Given this list of marker genes DHX57, ANAPC11, HEATR6, NME1, SOS1, SLC35F6 (solute carrier family 35 member F6), NCOR1, PIGL, HSD17B1, TUBD1, CD300LF, EPN2, GPS1, CCR7, TMEM97, MRPS23, BIRC6, RPL38, ALYREF, PAFAH1B1, CCDC47 (NCBI Gene Id 57003), GTF3C2, PRR11, SCO1, STX8, EIF4A3, CDC6, GJC1, FOXK2, SCPEP1, CTDNEP1, WSB1, CA10, MAP2K3, MCRIP1, WIPF2, ICAM2, KPNB1 (karyopherin subunit beta 1), SEC14L1, CEP95, SRP68, UTP18, SGSH, KIF18B, PHF23, EME1, PITPNA, STAT3, BRIP1, MRPL58, SRR, MYO1C, MRPL27, TACO1, MRPS7, NDUFAF8, NME2, JPT1, FLII, ARL16, SLC30A6, GAS7, MRPL10, PPM1D, BPTF, ANKFY1, MINK1, HCRT, MED9, PYCR1, NCBP3, LUC7L3, RPL23, ETV4, ACBD4 (acyl-CoA binding domain containing 4), MKS1, INTS2, BRCA1, EZH1, NTN1, SLC25A19, ATP2A3, SLC25A10, SNHG16, TMEM220, VTN, CTC1, POLG2, ANKFN1, AXIN2, HEXIM1, GOSR2, NUP85, MIR497HG, MYO18A, SMCR8, DUS1L, PSMC5, ALDH3A2, ATPAF2, CCL14, ZBTB4, ABCC3, NEURL4, NEK8, ALDOC, GPATCH11, SMURF2, KPNA2, ATP5MC1, SMC6 (structural maintenance of chromosomes 6), TMEM106A, LINC02210, GPRC5C, KSR1, FTSJ3, BAIAP2, SRSF2, SYNRG, SUMO2, TSEN54, AKAP1, LRRC59, EFCAB13, MRPL38, RNASEH1, ASGR1, NAT9, DHX40, ANKRD40, DHRS7B, SUPT4H1 (NCBI Gene Id 6827), TNFSF13, TOP2A, TK1, CBX2, RPS6KB1, GOSR1, PTRH2, TOM1L2, UTP6, RNF135, JMJD6, TIMM22, MRPL12, PHB1, NDEL1, CCDC144NL-AS1, NOL11, TMEM199, LBH, ARHGAP23, SLC38A10, RFFL, UBE2O, ULK2, KRTAP4-8, TBX2, TNFAIP1, BIRC5, ACADVL, MAP2K4, MSI2, ZNF18, MED13 (NCBI Gene Id 9969), MGC16275, RAD51C, P4HB, ATP5PD, RASD1, CRK, ARMC7, CHRNB1, TRPV2, GPS2, GEN1, DPH1, DCAF7, KHK, TRAPPC1, SMG8, FLOT2, RAB10, PMP22, SRSF1, here is a description of the gene set: Genes with copy number gains in primary neuroblastoma tumors. Human Gene Set: LASTOWSKA_NEUROBLASTOMA_COPY_NUMBER_UP species: Homo sapiens Identifying genes, whose expression is consistently altered by chromosomal gains or losses, is an important step in defining genes of biological relevance in a wide variety of tumour types. However, additional criteria are needed to discriminate further among the large number of candidate genes identified. This is particularly true for neuroblastoma, where multiple genomic copy number changes of proven prognostic value exist. We have used Affymetrix microarrays and a combination of fluorescent in situ hybridization and single nucleotide polymorphism (SNP) microarrays to establish expression profiles and delineate copy number alterations in 30 primary neuroblastomas. Correlation of microarray data with patient survival and analysis of expression within rodent neuroblastoma cell lines were then used to define further genes likely to be involved in the disease process. Using this approach, we identify >genes within eight recurrent genomic alterations (loss of 1p, 3p, 4p, 10q and 11q, 2p gain, 17q gain, and the MYCN amplicon) whose expression is consistently altered by copy number change. Of these, 84 correlate with patient survival, with the minimal regions of 17q gain and 4p loss being enriched significantly for such genes. These include genes involved in RNA and DNA metabolism, and apoptosis. Orthologues of all but one of these genes on 17q are overexpressed in rodent neuroblastoma cell lines. A significant excess of SNPs whose copy number correlates with survival is also observed on proximal 4p in stage 4 tumours, and we find that deletion of 4p is associated with improved outcome in an extended cohort of tumours. These results define the major impact of genomic copy number alterations upon transcription within neuroblastoma, and highlight genes on distal 17q and proximal 4p for downstream analyses. They also suggest that integration of discriminators, such as survival and comparative gene expression, with microarray data may be useful in the identification of critical genes within regions of loss or gain in many human cancers. from publication Łastowska M, Viprey V, Santibanez-Koref M, Wappler I, Peters H, Cullinane C, Roberts P, Hall AG, Tweddle DA, Pearson AD, Lewis I, Burchill SA, Jackson MS (PMID 17533364)